The following is a description of a gene set: Genes predicted to be targets of miRBase v22 microRNA mmu_miR_3113_5p in miRDB v6.0 with MirTarget v4 prediction scores > 80 (high confidence targets). from publication Chen Y, Wang X (PMID 31504780) Mouse Gene Set: MIR_3113_5P studied in species Mus musculus, and this is the list of marker genes: Pcdh7, Ppp1r42, Gprc5a, Cldn34b3, Gprc5b, Fam168a, Elf4, Lpcat3, Pappa, C2cd2, Creb1, Ptprj, Fam53c, Rfx5, Kdm6a, Gatad2a, Rab10, Tab3 (TGF-beta activated kinase 1/MAP3K7 binding protein 3), Opn3, Nefl, Ttyh2, Sorcs1, Col5a1, Prdx1, Mtmr2, Tecrl, Elmo2, Pipox, Pirt, Acvrl1, Vcf1, Gm5878, Syt2, Odf2, Niban2, Nt5c3, Zbtb33, Cbx6, Prdm16, Tfap2b, Nkx2-2, Ntrk2, A130010J15Rik, Homer1 (homer scaffolding protein 1), Trp53i11, Serpinf2, Map3k20, Klrb1b, Rhobtb3, Nxf1, Adcy1, Ogfod1, Phb2, 2510039O18Rik, Alox12, Raf1, Dcx, Kcna1, Gpm6b, Naga, Fgf6, Plch1, Ago3, Gapvd1, Tbc1d22b (TBC1 domain family, member 22B), Hs3st4, Spred1, Zfp704, Mbnl1, E130308A19Rik, Cdc42bpa, Zfp799, Ralbp1, Zfp36l2, Ubl4a, Mtf1